Given this list of marker genes MYO18A, COLEC11, MBL2, COLEC10, CFP, FCN3, FCN2, FCN1, PLA2G5, here is a description of the gene set: Any process that activates or increases the frequency, rate or extent of opsonization. Human Gene Set: GOBP_POSITIVE_REGULATION_OF_OPSONIZATION species: Homo sapiens